Given this list of marker genes SNORD116-1, COL1A2, TPM2, NEB, POR, NPAP1, ASH1L, CHST3, TPM3, ORC1 (origin recognition complex subunit 1), DST, SLC26A2, SHPK, ACY1, CFL2, SNORD115-1, PWRN1, KDM3B, SON, COL25A1, HNRNPK (heterogeneous nuclear ribonucleoprotein K), MKS1, SCN4A, HACD1, PEX1, IARS2, UBAP2L, ERGIC1, OPA1, DHCR7, CRTAP, PRKAG2, LMOD3, RNU4ATAC, PWAR1, FGFR3, KBTBD13, LTBP4, PIGA, SCYL2, PTPN23, COL1A1, DTYMK, ZNF699, HERC2, VARS1, MKRN3, RYR1, RMRP, KLHL40, MAGEL2, ACTA1, KLHL41, ASXL3, MYPN, UQCC2, MYH3, here is a description of the gene set: A position of the fetus at delivery in which the fetus enters the birth canal with the buttocks or feet first. species: Homo sapiens Breech presentation Human Gene Set: HP_BREECH_PRESENTATION